Given this list of marker genes TBC1D22A, CXCR3, CTRL, SLC24A1, WDR62, FUT6, COLGALT2, PAX7, SLC30A3, JADE3, DNAJC16, MSL3, HTR7, SLC2A1, LPGAT1, SLC4A3, C1orf216, ITIH4, INPP5E, CDYL, SLC13A2, AQP7, BMP10, PIAS2, BRCA1, AQP5, DPT (dermatopontin), BCL2, NTPCR, ERC1, ZNF133, ESR1, POLR2K, PIGR, SLC16A5, POU6F1, TAF5L, TAF2, AMFR, NCKIPSD, NRTN, SLC22A6 (solute carrier family 22 member 6), MC5R, PCF11, NKRF, MLN, IL13, GPR15, ABO (ABO, alpha 1-3-N-acetylgalactosaminyltransferase and alpha 1-3-galactosyltransferase), CACNB1 (calcium voltage-gated channel auxiliary subunit beta 1), UTRN, FOSL1, GPATCH8, ADCYAP1, PSG1 (NCBI Gene Id 91730), MAGEA9, EP400, ADAM20, SLC33A1, KLHL18, SEZ6L, CRHR1, KIAA0586, BRD1, ATP6V0A2, KRT33A, CHD9, ZNF500, WBP4, GRIK5, PSMF1, SMG1, MFN1, NR1I2, DRC3, PVR (NCBI Gene Id 5817), GJB5, SSTR5, TNFRSF25, MT4, RFC5, TLN2, COX6A2, P2RY10, FIG4, RUNX1, MSH3, HOXD4, KRT2, PIK3CB (NCBI Gene Id 5291, phosphatidylinositol-4,5-bisphosphate 3-kinase catalytic subunit beta), PIGB, FRYL, ZNF710, UBE4B, SULT4A1, NFX1, GLE1, PLEKHB1, FNTB, COL19A1, DAPK2, CYP11A1, KRR1, SCAMP1, ZBTB14 (NCBI Gene Id 7541), AFF2, IPCEF1, SYT5, CDK13, ATRX, GRIP2, KLHL20, ZNF592, KANK2, MC2R, PAXIP1, PAX9, NOS2 (nitric oxide synthase 2), EPHB2, COLQ, SPEF1, PDE6A, HNF1A, TBX19, CLPX, SYNJ2, RBBP8, ARFGEF2, MGA, POU6F2, PHF10, ZNF134, ZNF200, TTI1, JRK, TANC2, LTBP4 (latent transforming growth factor beta binding protein 4), POFUT2, RUNX2, NPFF, CAMK2G, PRELID3A (NCBI Gene Id 10650), TACC2, TMEM11, POP4, GPR19, ZNF157, HTR4, ADCY3, DTNA, AMMECR1, KRT86 (keratin 86), here is a description of the gene set: Neighborhood of RUNX1 runt-related transcription factor 1 (acute myeloid leukemia 1; aml1 oncogene) in the MORF expression compendium Neighborhood of RUNX1 Human Gene Set: MORF_RUNX1 species: Homo sapiens